Given this list of marker genes HYMAI, CYC1, HNF4A, MCCC2, KLF11, ABCC8, MMUT, CA5A (NCBI Gene Id 763), ITPR3, IVD, GCK, ACSF3, SUGCT, HNF1A, MRPL3, PTPN22 (protein tyrosine phosphatase non-receptor type 22), BTD (biotinidase), SHOX, IL6, ATP5F1D, CEL, NEUROD1, SLC12A3, OXCT1, CIDEC, EIF2AK3, CLCNKB, ACAT1, INS, PAX4, KCNJ11, PLAGL1, SLC16A1, INSR, GK, PDX1, DLD, BLK, DBT, ZFP57, APPL1, here is a description of the gene set: Human Gene Set: HP_KETOACIDOSIS Acidosis resulting from accumulation of ketone bodies. studied in species Homo sapiens Ketoacidosis